The following is a description of a gene set: A lack of facial expression often with staring eyes and a slightly open mouth. Human Gene Set: HP_MASK_LIKE_FACIES Mask-like facies species: Homo sapiens, and this is the list of marker genes: ADH1C, ATP13A2, TH, ACTA1, EIF2AK2 (NCBI Gene Id 5610), REV3L, PDGFB, UBE3A, ATXN8OS, PAX6, PIEZO2, PDGFRB, ITPR1, FA2H, POMT2, ATXN3, FKRP, PTRHD1, TRIM32, SMCHD1, DUX4, PABPN1, POMT1, UBA5, MRE11, FRG1, PLXND1, SLC20A2, GBA1, RIPK4, MAPT (NCBI Gene Id 8152), KCNJ6, TBP, DUX4L1, SLC6A8, TK2, ATP6AP2, HSPG2, NEUROG1, MT-TT, PANK2, DCTN1, ATXN2, PRNP, SNCAIP, LARGE1, ATP6V1A, POLG, MYH3, FMR1, UFC1, ATP7A, DNMT3B, FKTN, NR4A2